Given this list of marker genes CACNA1H, ABCC9, KCNJ10, DLG2, DLG4, NPTX1, SOD1, HSF1, CRHBP, SLC12A2, CYP11B1, NEK7, CYP11B2, STK39, here is a description of the gene set: Human Gene Set: GOBP_CELLULAR_RESPONSE_TO_POTASSIUM_ION species: Homo sapiens Any process that results in a change in state or activity of a cell (in terms of movement, secretion, enzyme production, gene expression, etc.) as a result of a potassium ion stimulus.